The following is a description of a gene set: part of: Signaling by VEGF Angiogenesis is the formation of new blood vessels from preexisting vasculature. One of the most important proangiogenic factors is vascular endothelial growth factor (VEGF). VEGF exerts its biologic effect through interaction with transmembrane tyrosine kinase receptors VEGFR, selectively expressed on vascular endothelial cells. VEGFA signaling through VEGFR2 is the major pathway that activates angiogenesis by inducing the proliferation, survival, sprouting and migration of endothelial cells (ECs), and also by increasing endothelial permeability. The critical role of VEGFR2 in vascular development is highlighted by the fact that VEGFR2-/- mice die at E8.5-9.5 due to defective development of blood islands, endothelial cells and haematopoietic cells. Reactome Pathway: VEGFA-VEGFR2 Pathway studied in species Homo sapiens, and this is the list of marker genes: NRAS, RAC1, PAK3, HSP90AA1, PRR5, VAV2, BRK1 (NCBI Gene Id 55845), NCKAP1L, NCKAP1, THEM4, MAPK14, CTNND1, SHC2, PRKCD, M, AHCYL1, MTOR, WASF1, ACTG1, MAPK12, CYFIP1, CDC42, AKT1, VAV1, MAPK11, PDPK1, MAPKAP1, CDH5, HSPB1, AKT3, ELMO1, KDR, TRIB3, PTK2, MAPKAPK2, DOCK1, ITGB3, SHB, CYBB, NCF4, ACTB, SH2D2A, HRAS, PIK3CA (phosphatidylinositol-4,5-bisphosphate 3-kinase catalytic subunit alpha), PRKCA, RICTOR, ITGAV, NCF2, PRKACB, ROCK1, ABI1, NCK2, PRKACG, PXN, SRC, PIK3CB, CALM1, SPHK1, CYBA, ROCK2, ABI2, CAV1, ITPR1, CRK, KRAS, MLST8, VAV3, AKT2, PRKCB, N, MAPK13 (NCBI Gene Id 5603), RASA1, PRKACA, WASF2, FYN, ITPR2, PTK2B, VEGFA, PIK3R2, BAIAP2, AXL, CTNNA1, MAPKAPK3, PRKCZ, CTNNB1 (NCBI Gene Id 1499), NCK1, NOS3, BCAR1, RHOA, PLCG1, NCF1, PIK3R1, JUP (NCBI Gene Id 3728), CYFIP2, PAK1, WASF3, PAK2, ELMO2, ITPR3